The following is a description of a gene set: species: Homo sapiens DNA damage caused by UV radiation initiates cellular recovery mechanisms, which involve activation of DNA damage response pathways, cell cycle arrest and apoptosis. To assess cellular transcriptional responses to UVC-induced DNA damage we compared time course responses of human skin fibroblasts to low and high doses of UVC radiation known to induce a transient cellular replicative arrest or apoptosis, respectively. UVC radiation elicited >3-fold changes in 460 out of 12,000 transcripts and 89% of these represented downregulated transcripts. Only 5% of the regulated genes were common to both low and high doses of radiation. Cells inflicted with a low dose of UVC exhibited transcription profiles demonstrating transient regulation followed by recovery, whereas the responses were persistent after the high dose. A detailed clustering analysis and functional classification of the targets implied regulation of biologically divergent responses and suggested involvement of transcriptional and translational machinery, inflammatory, anti-proliferative and anti-angiogenic responses. The data support the notion that UVC radiation induces prominent, dose-dependent downregulation of transcription. However, the data strongly suggest that transcriptional repression is also target gene selective. Furthermore, the results demonstrate that dose-dependent induction of cell cycle arrest and apoptosis by UVC radiation are transcriptionally highly distinct responses. Cluster d6: genes progressively down-regulated in WS1 cells (fibroblast) through 18 h after irradiation with high dose UV-C. from publication Gentile M, Latonen L, Laiho M (PMID 12907719) Human Gene Set: GENTILE_UV_RESPONSE_CLUSTER_D6, and this is the list of marker genes: MEIS2, TLE4, TRIB2, NFYA, PTK2, NCK1, AHDC1, NFIL3, PAFAH1B1, UGCG, CSTF3, CXCL12, ZNF146, SMAD3, EPS8, LPAR1, HMGXB4, CHTOP, MACIR, PUM2, STRN3, USP32P2, CDK7, ARL4C, BCAR3, ZMYND8, IGF2BP3, QKI (NCBI Gene Id 9444), MFAP1, PDGFRA, NFYB, PRRX1, FZD2, RAB14, IFNGR2